The following is a description of a gene set: Human Gene Set: GSE28130_ACTIVATED_VS_INDUCEED_TREG_UP from publication Kuczma M, Lee JR, Kraj P (PMID 21642545) studied in species Homo sapiens Induced and activated regulatory CD4+ Foxp3+ cells compared Genes up-regulated in activated versus induced T reg cells., and this is the list of marker genes: LRRN3, F3, ENDOD1 (endonuclease domain containing 1), KCNA1, ZNF460, LCT, CALCB, GSTO1, MED13, BCAT2 (NCBI Gene Id 587), ADTRP, BTF3P11, ASAP2, CD8B, ACP2, S1PR1, GFI1, MYC, KHDRBS1, IL5RA, SREBF2, ANKRD7, SLC4A7, SPINT2, RANBP2, STARD8, BCL2L11, RAB40B, ADAM17, SI, ZFP36L1, ARAF, ALB, DZIP3, LRCH1, ZCCHC14, HBEGF, HCFC1, ZFP69B, OSBPL8, CAPN2, SELL, CHST10, RSAD2, SLC12A5, VCAN, GPR183, SLA, DYNLT1, TCF4, LPIN2, PON3, ANGEL2, ADCY8 (NCBI Gene Id 114), SAA4, RAD23A (NCBI Gene Id 5886), CD8A, CYP7A1, JUN, ACD, IGSF3, GRK3 (G protein-coupled receptor kinase 3), PATJ (NCBI Gene Id 10207), SLC39A8, STRN (NCBI Gene Id 6801), ABAT, CCR5, S100A11, SEMA3D, IMMT (inner membrane mitochondrial protein, NCBI Gene Id 10989), RANBP6, PGAM2, WRN, USP2, SERPINC1, CD58, CNGA3, PEX2, WIF1, CD47, TMPRSS15, CD101, TP53BP2 (NCBI Gene Id 7159), TRIB2, NUP58, CCL4, ABHD5, CRIPTO, MYBL2, YWHAE, RBPJ, HPCA, TJP3, CASK, N4BP2L2-IT2, IFRD1, RYK, P2RY14, GIT2, PLA2G4A, MEOX2, SMPDL3A, SLC2A2, RECQL4, CNTN5, TPD52L1, MNAT1, RNF144A, CTNNA2, NDUFA7, BTF3P12, MYBPH, SEMG1, ZFR2, RPS12, HMGB3, TEX30, LSM1, ERC2-IT1, ASMT, UPP1, FOSL2, RABIF, SIRPB1 (NCBI Gene Id 93149), PRKX, CNTNAP2, ATRNL1, ELK3, SMARCC2 (SWI/SNF related, matrix associated, actin dependent regulator of chromatin subfamily c member 2), BCAS2, BEAN1, RABGGTB, GPX7, ST8SIA5, IGKV1D-13, DLC1, NME6, SOCS1, CXCL5, NRDC, SULF1 (NCBI Gene Id 23213), IL10, TMEM131L, KCNN3, SRP19, WASF3, PALLD, RASAL2, TGM3, APCS, GINS1, CASP1, GPS2, NFIL3, CCL3, RNASE2CP, FLT1, IL1RN, ELAVL4, MAP3K14, KRT34, LCP2, NDUFB5, EVI2B, SLC26A3, CRTAM, NDRG4, ART3, ADH7, RHOQ, TBC1D2B, REEP5, PPP2R3A, GUCY1A2, ARFGAP2, SNRPB, MAML3, HSPA4L, EVI2A, PTPRE, SV2C, CTCF, MAGEA12, IL10RA, F13B, KIAA1549L, GC, LPXN, KLRG1, ZNF208, KHDRBS3, H2AZ2, RGS16, NFATC3, PPP4R1, PTPRN2, ST6GAL1